Given this list of marker genes CHRNA1, CHRNA9, CHRNB2, CHRFAM7A, CHRNB4, CHRNA5, CHRNA2, CHRNB1, CHRNE, CHRND, CHRNG, CHRNA6, CHRNA3, CHRNB3, CHRNA7 (cholinergic receptor nicotinic alpha 7 subunit), CHRNA4, STXBP5, here is a description of the gene set: A homo- or hetero-pentameric protein complex that forms a transmembrane channel through which ions may pass in response to acetylcholine binding. studied in species Homo sapiens Human Gene Set: GOCC_ACETYLCHOLINE_GATED_CHANNEL_COMPLEX